Given this list of marker genes RARG, GRHL3, BCL10, PTCH1, SEC24B (NCBI Gene Id 10427), TSC1, KIF20B, MTHFD1, GLMN, SEMA4C, PLXNB2, DVL2, SKI, TMED2, SALL4, COBL, CLUAP1, DEAF1, PHACTR4, LMO4, STIL, FUZ, TULP3, APAF1, CITED2, TSC2, SPINT2, CC2D2A, PRKACA, IFT172, PRICKLE1, LHX2, MKS1, LIAS, SPECC1L, SPINT1 (NCBI Gene Id 8610), IFT122, TRAF6, SDC4, SFRP1, RALA (NCBI Gene Id 5898), FZD6, TGFB1, RGMA, FGF10, MED12, TRIM71, PFN1, TGIF1, TGFB2, WNT5A, RARA, NCKAP1, FOLR1, VANGL2, ABL1, ST14, CASP3, TWIST1, WDR83, MTHFR, VASP, OPA1, CDK20, RPS7, ALX1, CTHRC1, PAX2, CECR2, LRP2, ARHGAP35, CELSR1, FZD3, SCRIB, MTHFD1L, NOG, BMP4, PTK7, BBS4, TEAD2, DLC1, SUFU, GRHL2, SFRP2, PRKACB, BRD2, ADM, IFT57, ZEB2, KDM2B, KAT2A, here is a description of the gene set: Creation of the central hole of a tube in an anatomical structure by sealing the edges of an epithelial fold. Human Gene Set: GOBP_TUBE_CLOSURE studied in species Homo sapiens